The following is a description of a gene set: Mouse Gene Set: GOBP_LONG_CHAIN_FATTY_ACID_BIOSYNTHETIC_PROCESS species: Mus musculus The chemical reactions and pathways resulting in the formation of a long-chain fatty acid. A long-chain fatty acid has an aliphatic tail containing 13 to 22 carbons., and this is the list of marker genes: Alox12, Ptgs1, Alox15 (arachidonate 15-lipoxygenase), Asah2, Gstm2, Aloxe3, Elovl6, Acsbg2, Gstm6, Gstm4, Acsbg1, Acsl4, Abcd2, Acot8, Fads2, Gstp-ps, Gstp2, Gstp1, Acaa1a, Elovl5, Fads1, Acsbg3, Scp2, Elovl2, Alox5, Tmem135, Alox12b, Abcd1, Qki, Ltc4s, Acox1, Acaa1b, Gstm3, Plp1, Acot7, Myo5a, Tbxas1, Gstp3, Gstm7, Ehhadh, Gstm1, Hsd17b4, Alox8